Given this list of marker genes HEY1, FLT4, CREBBP, KAT2B, MAML3, MAMLD1, HES1, MAML1, SMAD3, NOTCH4, ACTA2, RBPJ, HEY2, SNW1, KAT2A, HES5, NOTCH2, EP300, NOTCH1, MAML2, here is a description of the gene set: Human Gene Set: REACTOME_NOTCH4_INTRACELLULAR_DOMAIN_REGULATES_TRANSCRIPTION NOTCH4 Intracellular Domain Regulates Transcription species: Homo sapiens